Given this list of marker genes WASL, EPHB2, PIK3R1, NRXN1, RAB17, AGRN, ARF6, NLGN1, CCR7, CDC42, DMTN, GPM6A, ABITRAM, PLPPR5, RAB3IP, MYO10, ZMYND8, NEURL1, SRF, NRP1, CCL21, TENM1, FNBP1L, MIEN1, DOCK11, MYO3A, ARHGAP44, DPYSL3, PALM, FMR1, PPP1R16B, DAAM2, STAU2, FSCN1, SRGAP2C, RIPOR2, CLN3, GAP43, RALA, TGFBR1, PRKCD, TRPM2, RAB5A, RHOQ, ARAP1, TGFB3, MYO3B, TENM2, here is a description of the gene set: studied in species Homo sapiens Human Gene Set: GOBP_REGULATION_OF_FILOPODIUM_ASSEMBLY Any process that modulates the frequency, rate or extent of the assembly of a filopodium, a thin, stiff protrusion extended by the leading edge of a motile cell such as a crawling fibroblast or amoeba, or an axonal growth cone.